The following is a description of a gene set: Genes down-regulated in CD4 T cells: medium versus TGF beta and IL6. STAT3, an essential transcription factor with pleiotropic functions, plays critical roles in the pathogenesis of autoimmunity. Despite recent data linking STAT3 with inflammatory bowel disease, exactly how it contributes to chronic intestinal inflammation is not known. Using a T cell transfer model of colitis we found that STAT3 expression in T cells was essential for the induction of both colitis and systemic inflammation. STAT3 was critical in modulating the balance of T helper 17 (Th17) and regulatory T (Treg) cells, as well as in promoting CD4+ T cell proliferation. We used chromatin immunoprecipitation and massive parallel sequencing (ChIP-Seq) to define the genome-wide targets of STAT3 in CD4+ T cells. We found that STAT3 bound to multiple genes involved in Th17 cell differentiation, cell activation, proliferation and survival, regulating both expression and epigenetic modifications. Thus, STAT3 orchestrates multiple critical aspects of T cell function in inflammation and homeostasis. Human Gene Set: GSE21670_UNTREATED_VS_TGFB_IL6_TREATED_CD4_TCELL_DN from publication Durant L, Watford WT, Ramos HL, Laurence A, Vahedi G, Wei L, Takahashi H, Sun HW, Kanno Y, Powrie F, O'Shea JJ (PMID 20493732) species: Homo sapiens, and this is the list of marker genes: RPS27A, HNRNPH1, ST13P4, CCDC59, RPS3A, ATP5MC3, AMZ1, MIR202, LINC03006, MICOS10, OR51F2, RPL29, MRPL51, PRKCA, NDUFA12, FUS, REP15, SNORD41, CACUL1 (NCBI Gene Id 143384), MIR9-1, SLC16A10, RPS15A, S100A6, SYNJ2BP (NCBI Gene Id 55333), OSTCP1, FSD1L, CROT, TMEM14C, COX16, DPYSL3, SYDE2, SLC4A10, UQCRBP1, RPLP2, SNORA22, RPL5, SCOC-AS1, CSTF3, MYL12BP2, ARHGEF6, ZNF589, DPM1, HMGB3P24, RAB11A, EEF1AKMT1, SPACA3, HSD3BP4, FDPS (farnesyl diphosphate synthase), TRIM7, OCIAD1, RPS25, EPCAM, C2CD2, PMF1, PDHB, CGREF1, UNC80, RPL26, APTX, RETNLB (NCBI Gene Id 84666), OR56A4 (NCBI Gene Id 79271), TGDS, DNTT, SLC22A25, STX1B, COX7C, TFAM, PFN2, ENSG00000124835, FAM230B, TAL1, OSGIN2, NNMT, JAML, PPP2R2C (NCBI Gene Id 5522), FLG, COPRS, GEMIN6, RPS27, SLC2A2, KCTD18, SELENOF, APPBP2, CCDC110, ADGRG6, GPR158, GMFG (NCBI Gene Id 9535), LINC00314, MAGOHB, KU-MEL-3, ZNF607, TSC1, GARIN1B, ZNF479, SLC18A2, DNAJB13, MICU3, RPS6KB1, LYRM1 (LYR motif containing 1), BMP3, EIF3E, SYNGR1, TAS1R1, PTS, WDR36 (NCBI Gene Id 574015), C1QBP, WDR17, TCTN1, MCEMP1, PDZD2, NOP10, MRPS23, PGRMC2, PDE6H, PRODH2, ESD, HSD17B12, SNORA2B, PSMB1, SUCLG2, RPS7, RPL23P8, MRPL20, MIR214, RTN4IP1, TRA2B, RPL30, DPF1, GLT8D2, EBNA1BP2, MIR185, TAF15, POMP, HTR1D, YTHDC1, COX6C, SRSF9, COX18, CCDC12, ATP5MK, RNU11, ALPI, SERPINB10, DECR1, MAGOH, RPL10A, RPL6, USP44, ATAD1 (NCBI Gene Id 84896), NTN1, MORN2, OVGP1, ZNHIT6, POLR1B, RPS17, NIT2, ADGRE1, RPL17, XKR4, LRIT3, SEC61G, RPL9, PGGT1B, PM20D1, EPHX2, MTMR1, ADSS2, CUL2, CDC42, PHOX2B, FAM86C1P, HOXC12, LIPC, CHRDL2, SYNCRIP, SNRPA1, AK5, NDUFS6, SNRPE, PSMG2, RPSAP15 (NCBI Gene Id 220885), PLAC8, EIF2S1, SLC12A1, ZNF45, RPL37AP8, LRP2BP, RPL27, SAR1A, EIF2A, OR1D2, KRTAP20-2, RFC3, SNORD21, ALG8, RPS29, HINT1